The following is a description of a gene set: species: Mus musculus Genes predicted to be targets of miRBase v22 microRNA mmu_miR_34c_3p in miRDB v6.0 with MirTarget v4 prediction scores > 80 (high confidence targets). from publication Chen Y, Wang X (PMID 31504780) Mouse Gene Set: MIR_34C_3P, and this is the list of marker genes: Slc2a13, Ccr3, Prkar2b, U2af1, Pacsin2, Flt3, Serpinf2, Amot, Wdr48, Tut4, Pycard, Bpnt2, Eif4e, Zdhhc21, Tmem33, Mob1b, Gbp8, Zfp2 (zinc finger protein 2), Dcp2, Lias, Gm2042, Gpc6, Camk4, Tcaim, Trpm1, Clca4b, Sft2d3, Rlim, Fam120a, Fzd2, Ifi209, Atp11c, Trmt1l, Otud6b, Tmem237, Gpr82, Pcdhb14, Nckap1, Cand1, Magi3, Exosc1, Abhd13, Cd226, Dnase2b